The following is a description of a gene set: Any process that modulates the activity of a ryanodine-sensitive calcium-release channel. The ryanodine-sensitive calcium-release channel catalyzes the transmembrane transfer of a calcium ion by a channel that opens when a ryanodine class ligand has been bound by the channel complex or one of its constituent parts. Human Gene Set: GOBP_REGULATION_OF_RYANODINE_SENSITIVE_CALCIUM_RELEASE_CHANNEL_ACTIVITY species: Homo sapiens, and this is the list of marker genes: CAMK2D, CALM1, JPH2, CALM2, SELENON